Given this list of marker genes IL23R, JAK2, IL23A, IL12B, IL12RB1, STAT4, P4HB, TYK2, STAT3, here is a description of the gene set: Human Gene Set: REACTOME_INTERLEUKIN_23_SIGNALING studied in species Homo sapiens Interleukin-23 signaling